The following is a description of a gene set: Catalysis of the reaction: NADPH + H+ + O2 = NADP + hydrogen peroxide (H2O2). species: Homo sapiens Human Gene Set: GOMF_NADPH_OXIDASE_H202_FORMING_ACTIVITY, and this is the list of marker genes: FMO5, NOX4, DUOX1, MICAL1, DUOX2